Given this list of marker genes TRMT1L, TRMT5, METTL1, TRMT1, TRMT10A, TARBP1, THUMPD3, THUMPD2, TRMT10C, TRMT10B, TRMT11, FTSJ1 (NCBI Gene Id 4408), here is a description of the gene set: species: Homo sapiens Catalysis of the reaction: S-adenosyl-L-methionine + guanosine in tRNA = S-adenosyl-L-homocysteine + tRNA containing methylguanine. Human Gene Set: GOMF_TRNA_GUANINE_METHYLTRANSFERASE_ACTIVITY